The following is a description of a gene set: Neuotransmitter uptake by astrocytes is mediated by a specific transporter located on the astrocytic membrane. The imported neurotransmitter is metabolized and transported back to the neuron. studied in species Homo sapiens part of: Transmission across Chemical Synapses Reactome Pathway: Neurotransmitter uptake and metabolism In glial cells, and this is the list of marker genes: SLC1A2, GLUL, SLC38A1, SLC1A3